Given this list of marker genes Ifnar1 (NCBI Gene Id 15975), Pde2a, Ppp1r3e, Cbfa2t3, Chchd2, Oas1e, Nupr1, Ppp2ca, Phka1, Ifng (NCBI Gene Id 15978), Arnt (NCBI Gene Id 51910), Irs1, Akt1, Slc25a12, Il4, Prkag3, Hif1a, Oas1c, Mtor, Prkag2 (protein kinase, AMP-activated, gamma 2 non-catalytic subunit), Atp7a, Sik2, Epm2aip1, Apoc3, Oas1h, Pask, Mfn2, Khk (NCBI Gene Id 16548), Prxl2c, Src, Htr2a, Trex1, Mtch2, Tigar, Phkg1, Cdk1, Rptor, Kat2b, Adcy10, 1810024B03Rik, Aldob, Pomc, Grb10, Cxxc5, Ccnb1, Slc2a6, Pik3ca, Abcd1, Dyrk2, Gck, Prkaca, Git1, Oas1g, Gpi1, Ddit4, Ppp1r3d, Gsk3b, Macroh2a1, Myc, Trp53, Irs2, Phlda2, Oas1f, Sirt6, Ppargc1a, Opn3, Ppp1r3g, Ier3, Trpv4, Mlx, Prdm16, Chchd4, Ppp1r3b, Chchd2-ps, Slc4a1, Phkg2, App, Igf1, Oas1a, Hmgb1, Gcgr, Ifnlr1, Rbpj, Prelid1, Arl2, Hdac4, Ppp1r3a, Akt2, Mlxipl, Zbtb20, Ncor1, Oas1d, Tnf, Slc25a23, Park7, Nkx1-1, Enpp1, Ppara (NCBI Gene Id 399624), Ccnb1-ps, Gpd1, Vcp, Ppp1cb, P2rx7, Slc25a33, Pink1, Prkag1, Ak4, Tmem135, Rhoa, Pfkfb1 (NCBI Gene Id 18639), Il3, Flcn, Phkb (NCBI Gene Id 213944), Oas1b, Adra1b, Sorbs1, Iscu, Psen1, Hsd11b1, Ep300, Shmt2, Cisd1, Mlst8, Il10rb, Nop53, Ins2, Actn3, Eif6, Zbtb7a, Fbp1, Ppif (peptidylprolyl isomerase F (cyclophilin F)), Prkaa1, Prkaa2, Ide, C1qtnf2, Gfpt1, Rubcnl, Inpp5k, Myog, Ogt, Slc4a4, Tefm, Jmjd8, Trap1, Ins1, Insr, Ppp1r3f, Ppp1ca, Cavin3, Uchl1, Dnajc15, Stat3 (NCBI Gene Id 68733), Uqcc2, Gapdhs, Pth, Ppp1r3c, Igf2, Pnpt1, Esrrb, Trim63, here is a description of the gene set: species: Mus musculus Any process that modulates the frequency, rate or extent of the chemical reactions and pathways resulting in the formation of precursor metabolites, substances from which energy is derived, and the processes involved in the liberation of energy from these substances. Mouse Gene Set: GOBP_REGULATION_OF_GENERATION_OF_PRECURSOR_METABOLITES_AND_ENERGY